The following is a description of a gene set: Human Gene Set: MIR138_1_3P studied in species Homo sapiens from publication Chen Y, Wang X (PMID 31504780) Genes predicted to be targets of miRBase v22 microRNA hsa-miR-138-1-3p in miRDB v6.0 with MirTarget v4 prediction scores > 80 (high confidence targets)., and this is the list of marker genes: SYNRG, NEU3, OXSR1, PGM2, WDFY2, CPPED1, SLC4A4, RBMXL2, USP24, FUT9, TRAF3IP1, RANBP9, DCAF7, G3BP1, LUZP1, GBE1, TIPRL, GXYLT1, PHACTR2 (phosphatase and actin regulator 2), DDB1, COQ9, HPS3, SLC5A5, YIPF4, NBN, EMX2, DDI2, ALCAM, CERS3, SMC6, DPP6, MEGF10, GPATCH8, ABI1, RAB3B, BAG4, CNTNAP5, SPRED1, CLEC1A, BRPF3, SH2D4A, ATE1, LYPD6, PLEKHM3, RAB4A, NYAP2, ASXL1, GNPNAT1, NCAN, THUMPD1, RALB, ERBB4, GASK1B, EAF1, NDUFAF5, RPIA (NCBI Gene Id 22934), DCT, AQP11, TXLNB, TET3 (tet methylcytosine dioxygenase 3), C15orf61, TOGARAM2, ZNF681, AS3MT, ZNF770, RC3H1, ZNF428, RBM12B, SAMD12, KLLN, ANO6, ING1, IRF9, RPL15, RASSF3, ATRN, GMNC, RAB3GAP1, USP4, SOCS4, ZNF275, DNMT3B